Given this list of marker genes THBS1, MYO10, MLF1, TSPAN8, SAR1B, MPHOSPH9, MDM2, MEAK7, CSGALNACT1, TBX3, FCHSD2, MSX2, WWC3, ESR1, SLPI, ST6GALNAC2, RAMP1, GFUS, PGRMC1, ANKLE2, SMPDL3A, BST2, PCDH7, PDZK1IP1, ERGIC2, PSIP1, S100A8, GPRC5B, MCF2L, ACSL1, KCNMA1, PSME4, EIF2AK2, OASL, IGFBP4, NPEPPS, QPRT, ABCA12, NDNF, ASS1, PLAAT3, TMSB15A, SPRED2, TMT1A, CCNDBP1, AKR1D1, SUZ12, DIP2C, WDR19, COL9A3, CHST15, MAOB (NCBI Gene Id 4129), IKBKB, TFF1, SERPINA5, FABP7, PDLIM1, ACE2, TMPRSS2, STK39, KIT, CROT, PI3, PEX3, PAPSS2, PON2, MKNK2, ALDH1A3, GALNT3, RBBP8, FGFR2, CTBS, UGT2B11, ORM1, TRAF5, MARCHF3, PRKAR2B, MYL6B, GREB1, GGT1, RTN1, ERO1A, MICB, TSPAN3, SCD, SCCPDH, CACNA2D2, POLG2, CHST1, ACSL3, BLNK, RALGPS1, PNISR, IFI35, STEAP3, SCUBE2, CRABP2, CSTB, CXCL8, BNIP3, CLIC3, PALS2, ETFA, TRPV6, NAMPT, AK4, TTYH1, SERHL, TMX4, CLU, DUSP14, AGPS, MED13, CRYBG1 (crystallin beta-gamma domain containing 1), SERHL2, S100A13, ACAD8, PLCH1, EFHD1, RNF11, APLP2, BMI1 (NCBI Gene Id 648), PHKB, CPQ, BAG1, KMO, MANSC1, HSD17B2, NUDT15, ECHDC1, MORC4, TPGS2, IGF1R, PFKM, IDH1, SMARCD3, YAP1, AKR1B10, SCGB1D2, IDH2, LAMB2, MACIR, PLEKHB1, GFRA1, TUBA4A, BRINP3, REEP5, KRT7, TMEM87A, CES1, G6PD, EGR3, PIK3CB, PNP, TBC1D9, NRAS, PNMA1, TFF3, FKBP5, DAP, SSR1, DDAH2, TRIM36, NME3, QSOX1, SLC31A1, PKP2, HPRT1, SWAP70, ARL3 (NCBI Gene Id 403), FAM106A, EGFR, VLDLR, TRPS1, C3orf52, HMGCS1, PER3, RMND1, PLAAT1 (phospholipase A and acyltransferase 1), PAM, TASOR2, CLDN8, MYH10, SPTLC2, HGD, CPA3, OPTN, COMT, AR, FDFT1, RNF141, SLF2, MAP3K5, ASB13 (ankyrin repeat and SOCS box containing 13), RABGAP1L, CYB5A, NDRG1, ANKRD27, PMAIP1, PLCL1, CLSTN2, TBL1X, ARNT2, INPP5F, UCP2, TLE1, MSMO1, MEIS3P1, LIMCH1, RNF24, SEPHS2, HSD17B4, DCAF10, IL6ST (interleukin 6 cytokine family signal transducer), YBX1, EVL, CLDN1, AZGP1, SGMS1, MTFR1, MCCC1, LDOC1, NAAA, UCHL3, FCN2, MIA3, HMGN4 (high mobility group nucleosomal binding domain 4), RIOX2, NPY1R, TNFSF4 (NCBI Gene Id 7292), MAP2K6, ALCAM, ZDHHC17, HEBP2, SRD5A1, AMACR, DHCR24, DNALI1, SETMAR, SMARCE1, MAOA, HDGFL3 (NCBI Gene Id 50810), PPIF, AGFG1, ANXA9, CYP2J2 (NCBI Gene Id 1573), C2CD5, TPSAB1, BCL2, MED13L, STK32B, ATP7A, SMCO4, SEC23B, C14orf132, PCSK6, ABCC5, RTP4, KYNU, DDC, PRKAA1, ELOVL2, WIPF2, TFAP2B, ACAA2, LBP (NCBI Gene Id 3929), PDZD2, NOTCH2NLA, CHN2, ACADM, ACOT7, GHR (NCBI Gene Id 2690), MTUS1, ANP32E, DHCR7, ADM, S100A14, GALE, CLCA2, MPHOSPH6, ENO2, GATA3 (GATA binding protein 3), TACC2, STYK1, MZT2A, PGK1, KPNB1, NBR1, SREK1, CCDC6, U2SURP, OPN3, APOD, AKR1A1, MPZL1, ULK2, GNMT, RLN2, PIP, TRMT1L, SMAD3, ABCC6, SYCP1, ZDHHC4, VEGFA, CDKN1B, FAR2, RAB38, GMPS, DBNDD2, FASN, EIF4EBP1 (NCBI Gene Id 1978), TK1, GGTLC1, OAZ3, P4HA1, SYNGR3, RESF1, TESMIN, ABHD2, DBI, S100A9, ADAM9, VEZF1, ETFB, BTG2, ALDH3B2, here is a description of the gene set: Previous microarray studies on breast cancer identified multiple tumour classes, of which the most prominent, named luminal and basal, differ in expression of the oestrogen receptor alpha gene (ER). We report here the identification of a group of breast tumours with increased androgen signalling and a 'molecular apocrine' gene expression profile. Tumour samples from 49 patients with large operable or locally advanced breast cancers were tested on Affymetrix U133A gene expression microarrays. Principal components analysis and hierarchical clustering split the tumours into three groups: basal, luminal and a group we call molecular apocrine. All of the molecular apocrine tumours have strong apocrine features on histological examination (P=0.0002). The molecular apocrine group is androgen receptor (AR) positive and contains all of the ER-negative tumours outside the basal group. Kolmogorov-Smirnov testing indicates that oestrogen signalling is most active in the luminal group, and androgen signalling is most active in the molecular apocrine group. ERBB2 amplification is commoner in the molecular apocrine than the other groups. Genes that best split the three groups were identified by Wilcoxon test. Correlation of the average expression profile of these genes in our data with the expression profile of individual tumours in four published breast cancer studies suggest that molecular apocrine tumours represent 8-14% of tumours in these studies. Our data show that it is possible with microarray data to divide mammary tumour cells into three groups based on steroid receptor activity: luminal (ER+ AR+), basal (ER- AR-) and molecular apocrine (ER- AR+). Genes which best discriminate between two groups of breast cancer according to the status of ESR1 and AR: apocrine (ESR1- AR+) and luminal (ESR1+ AR+). species: Homo sapiens Human Gene Set: FARMER_BREAST_CANCER_APOCRINE_VS_LUMINAL from publication Farmer P, Bonnefoi H, Becette V, Tubiana-Hulin M, Fumoleau P, Larsimont D, Macgrogan G, Bergh J, Cameron D, Goldstein D, Duss S, Nicoulaz AL, Brisken C, Fiche M, Delorenzi M, Iggo R (PMID 15897907)